Given this list of marker genes TSEN34, NDUFB7, PIK3C2A, NSRP1, SIN3A, TUBA1A, TBCK (NCBI Gene Id 93627), KAT5, PRORP, PTDSS1, RTTN, ODC1, PPP1R12A, AGTPBP1 (ATP/GTP binding carboxypeptidase 1), FAT4, DCHS1, SON, NONO, PIGH, TUBA8, SEPSECS, SVBP, EARS2, ZNF462, PLXNA1, ATAD3A, C2orf69, SIN3B, PUS3 (NCBI Gene Id 83480), HSPA9, DDB1, WARS1, LMNB1, DENND5A, TSEN2, ATPAF2, TSEN15, TSEN54, GPSM2, SNF8, KIAA0586, STXBP1, NT5C2, MCOLN1, THOC6, here is a description of the gene set: Dysplastic corpus callosum Human Gene Set: HP_DYSPLASTIC_CORPUS_CALLOSUM Dysplasia and dysgenesis of the corpus callosum are nonspecific descriptions that imply defective development of the corpus callosum. The term dysplasia is applied when the morphology of the corpus callosum is altered as a congenital trait. For instance, the corpus callosum may be hump-shaped, kinked, or a striped corpus callosum that lacks an anatomically distinct genu and splenium. studied in species Homo sapiens